The following is a description of a gene set: Neighborhood of GLTSCR2 studied in species Homo sapiens Human Gene Set: GNF2_GLTSCR2 Neighborhood of GLTSCR2 glioma tumor suppressor candidate region gene 2 in the GNF2 expression compendium, and this is the list of marker genes: RPL30, RPL38, RPL19, ARHGEF18, RPS29 (NCBI Gene Id 6235), RPL3, EEF1B2, RPS27, RPLP1, RPL34, RPL23A, RPL18, RPL12, FAU, RPL28, EEF1D (eukaryotic translation elongation factor 1 delta), EEF1G (eukaryotic translation elongation factor 1 gamma), RPL18A, RPS14, RPS19, RPS9, RPLP2, RPL35, RPL13, RPL13A, NOP53, RPS21, RPL35A (ribosomal protein L35a), RPS10, RPS15, RPS16